The following is a description of a gene set: Signaling by NTRKs Mouse Gene Set: REACTOME_SIGNALING_BY_NTRKS studied in species Mus musculus, and this is the list of marker genes: Mapk7, Rps6ka1, Irs2, Shc1, Shc3, Ap2s1 (NCBI Gene Id 232910), Ppp2r5d, Ntrk2, Srf, Ap2a2, Rapgef1, Grb2, Rps6ka2, Ntf3, Ppp2cb, Dusp3, Egr2, Sgk1, Dusp4, Sos1, Ntrk3, Braf, Ppp2ca, Rap1a, Furin, Creb1, Crk, Mapk1, Mapkapk2, Mapkapk3, Bdnf, Pik3r2, Hras, Mapk3, Plcg1, Ap2b1, Cltc, Pcsk5, Kras, Crkl, Pcsk6, Ntrk1, Ywhab, Mapk11, Dusp7, Nab2 (NCBI Gene Id 216451), Chd4, Ppp2r1a, Ap2a1, Pik3cb, Kidins220, Map2k1 (NCBI Gene Id 26395), Rhoa, Fyn, Map2k2, Pik3r1, Rac1, Vrk3, Ppp2r1b, Pik3ca, Mapk14, Frs2, Ralgds, Ap2m1, Ntf5, Sh3gl2, Rps6ka3, Dnal4, Src, Atf1, Dusp6, Clta, Rps6ka5, Ngf (nerve growth factor), Shc2